The following is a description of a gene set: Mouse Gene Set: REACTOME_BINDING_AND_UPTAKE_OF_LIGANDS_BY_SCAVENGER_RECEPTORS Binding and Uptake of Ligands by Scavenger Receptors studied in species Mus musculus, and this is the list of marker genes: Igkv2-137, Apol9a, Msr1, Ighv8-13, Ighv3-3, Igkv1-132, Scgb3a2, Hbb-bt, Apol10a, Ighv5-12, Ighv13-2, Hpx, Apol11b, Igkv18-36, Igkv1-133, Igkv1-122, Ighv5-4, Ighv8-11, Marco, Iglc1, Ighv8-5, Cd163, Ighv6-7, Igkv2-109 (immunoglobulin kappa variable 2-109), Calr, Apoe, Lrp1, Ighv5-15, Ighv8-12, Hbb-bs, Ighv3-1, Ighv8-9, Ighv6-4, Ighv5-17, Ighv6-6, Apob, Cd36, Igkv20-101-2, Ambp, Ighv5-9-1, Ighv5-2, Stab2, Apol9b, Igkv1-117, Ighv3-6, Ighv12-3, Iglc2, Ighv3-8, Ighv5-9, Igkv1-35, Igkv11-125, Ighv7-2, Igkv15-103 (NCBI Gene Id 692169), Igkv1-110, Apol7e, Apol10b, Ighv16-1, Igkv1-88, Hp, Ighv8-6, Apol7c, Igkv1-131, Ighv5-6, Igkv17-121, Ighv7-3, Apol7a, Igkv1-99, Ighv3-4, Igkv2-112, Ighv8-2, Apoa1, Apol7b (NCBI Gene Id 278679), Hba-a1, Alb, Jchain, Igll1, Igkv8-21, Apol8, Hsp90b1, Stab1, Scarb1, Igkv16-104, Ighv5-12-4, Masp1, Ighv8-4, Ighv5-16, Colec11, Ighv6-3, Apol11a, Ighv7-4, Ighv8-8, Igha, Sparc, Ighv6-5, Igkv1-135, Ighv3-5